Given this list of marker genes NECTIN1 (nectin cell adhesion molecule 1), BLM, FGF3, TP63, CEP152, CDH1, FGFR1, B3GLCT, NAA10, TGFA, WNT10B, ADAMTS15, GJA1, IRF6, SUMO1, TCF12, LRP6, ERCC3, EDA, DLX3, GREM2, AXIN2, PAX9, EDARADD, ATP6V1B2, CDC42BPB, MSX1, DLX4, RIC1, ARHGEF38, CDH11, DLG1, EIF4A3, ATR, BMP4, COBLL1, FLNA, ARHGAP29, PDGFRA, DDX59, CDH3, GLI2, NEK1, RIPK4, WNT10A, BCOR, here is a description of the gene set: species: Homo sapiens Agenesis specifically affecting one of the classes incisor, premolar, or molar. Selective tooth agenesis Human Gene Set: HP_SELECTIVE_TOOTH_AGENESIS